The following is a description of a gene set: studied in species Homo sapiens Human Gene Set: GOBP_REGULATION_OF_TRANSMEMBRANE_RECEPTOR_PROTEIN_SERINE_THREONINE_KINASE_SIGNALING_PATHWAY Any process that modulates the rate, frequency, or extent of the series of molecular signals generated as a consequence of a transmembrane receptor serine/threonine kinase binding to its physiological ligand., and this is the list of marker genes: RBPJ, GDF11, SAP30L, GDF2, SPRED2, MIR26A1, ADAMTSL2, ZNF703, KIAA0319, ERFE, XBP1, SDCBP, MIR106A (microRNA 106a), GIPC1, NUP93, TSC22D1, SMAD7, CILP, MIR98, SNX6, WFIKKN2, MIR195, UBE2D3, MIR373, LRP2, NOMO1 (NODAL modulator 1), MEN1, MIR26B, RBBP7, MIRLET7A1, SH2B1, NEO1, SAP30, TGFBR2, FOXD1, MIR181A2, MIR490, PPM1A, CHST11 (NCBI Gene Id 55807), SFRP4, RNF111, LRRC32, GPR155, DACT1, SKOR2, BMPER, CHRDL1, EID2, IL17F, SHH, PSG9, FZD1, SULF1, CER1, CDH3, NBL1, ACVR2B (NCBI Gene Id 93), PELO, NGLY1, ING2, RBBP4, MIR18A, MIR497, MIR204, GATA4, GDF5, STK11, PDPK1 (NCBI Gene Id 5170), PCSK6, SORL1, PRMT1, TMEM53 (transmembrane protein 53), NPNT, USP15, FBN2, ZC3H3, FSTL5, FOLR1, NOG, PIN1, MIR27B, GDF3, DKK1, CD109, ONECUT1, SUDS3, KCP, MIR21, CHRDL2, BRMS1, NRROS, FKBP1A, STUB1, SCUBE3, CITED1, PPARG, HSPA5, MIR130A, MIR142, ZNF451, ACVR2A, MIR372, TET1, GOT1, MIR302C, INHBA, GDF6, CAV1, VWC2L, ILK, TBX20, BRMS1L, LOX (lysyl oxidase), BMP2, MIR145, CITED2, SNW1, MIR125B1, TTK, UBE2D1, CIDEA, ARID4A, FLCN, BMP6, MAGI2 (membrane associated guanylate kinase, WW and PDZ domain containing 2), CRB2, BMPR1A, MIR361, HSP90AB1, ATOH8, FBN1, MSX1, SKIL, HJV, LEMD3, LDLRAD4, MIR323A, PEG10, NCLN, CHRD, MIR20A, ING1, TFAP2B, VASN, CCN1, LTBP4, SIN3A, MIR424, MIR15B (NCBI Gene Id 406949), GPC3, ZEB1, CREBBP, SPRED1, STRAP, HTRA3, ADISSP, TP53, ELAPOR2, FSTL3, BMP5, MIR564 (NCBI Gene Id 693149), SMAD4, XIAP, FBXL15, TGFB3, VWC2, SLC2A10, MIR520C, FAM89B, ZBTB7A, BAMBI, SKOR1, LATS1, MIRLET7F1, CRIM1, MSX2, ITGA8, MIRLET7B, MIR30B, TGFB1, MIR214, SPRED3, MIR210, HES5, TGFBR1, DLX1, GREM1, HFE, TOB1, PBLD, LTBP1, BMP10, NREP, FKBP1C, SMAD6, IGSF1, EMILIN1, BCL9, HSPA1A, TWSG1 (NCBI Gene Id 57045), ARID4B, GLG1, AMH, MIR27A, FERMT1, ACVR1B, SOSTDC1, SFRP1, DKK3, THBS1, HTRA4, LATS2, FSTL1, MTMR4, CDKN1C, MIR302B, MIR100, HES1, MIR498, CSNK2B, MYOCD, WNT5A (NCBI Gene Id 7474), RASL11B, ENG, MIR23A, SFRP2, SMURF1, HDAC1, ZEB2, MIR885, HOXA13, SMAD2, DAND5, NOTCH2, FGF10, NOMO3, TGFB1I1, HIPK2, MIR199A1, ASPN, BMP7, KDR, SMURF2, CAV2, SMAD5-AS1, SPRY1, MIR9-1, FGF9, PMEPA1, RGMA, PRDM16, PPARA, ARK2C, IL17RD, GREM2, SMAD3, INTS9, CDH5, SNX25, ACVR1, SPART, CDKN2B, ITGA3 (NCBI Gene Id 4454), BMPR2, MIR140, MIR101-1, MIR29B1, HDAC2, CTDSPL2, ABL1, WNT1, MIR342, TGFBR3 (transforming growth factor beta receptor 3), ACVRL1, MIR19B1, MIR483, SINHCAF, MIR205, RBPMS2, NUMA1, DACT2, HTRA1, NOTCH1, WFIKKN1, FKBP8, MIR19A, TRIM33, MIR376C, UCMA, MIR93, PALS1, CAV3, ADAM17, SOX11, BMP4, UBE2O, NKX2-1, TMPRSS6, ONECUT2, CRKL, SKI, CCN3, LRG1, TGFBR3L (transforming growth factor beta receptor 3 like), MIR199B, SIRT1, FSTL4 (follistatin like 4), MIRLET7G, AXIN1, DAB2, GLCE, FST, MIR17, PARP1, MECOM, DMRT1, GDF7, TNFAIP6, OVOL2, JAK2, ZNF423, SOST, GDF15, SAP130 (NCBI Gene Id 79595), LRP1, MIR146A, VEPH1, SPRY2, NODAL, TGFB2 (transforming growth factor beta 2), OGT, MICOS10-NBL1, EP300, BCL9L